Given this list of marker genes DDRGK1, NALF2, CREB3L1, ZSCAN26, GIPC1, DIRAS1, ARHGEF11, MBD3L5, CAMK2A, SLA2, DNMT3A, TNRC18 (NCBI Gene Id 84629), ADAMTS19 (NCBI Gene Id 171019), MBD6, SLC4A1, PTGFRN, KMT2D, ATP6V0A1, DPP9, BCL7A, ZBTB4, EPHA8, BCAM, SETBP1, BHLHE40, MEOX1, FAM222A, ANO10, FOXP4, SLC6A8, ARF3, ARPP19, COL5A3, B4GALNT1, TUBB, RALGPS1, DMPK, UBAP2, MLLT6, MAT2A, MBD3L4, HOXC4, LRFN2, RNF208, WAS, HELZ2, DUSP8, SYT7, MAVS, PRDM11, PLA2G2D, HNRNPUL1, PPP1R9B, CASTOR2, ZNF385A, C2CD2L, MYO18A, AR, RANBP10, ZNF764, BAZ1B, MTA1, HNF4A, PLEKHM1, NPTXR, UGT3A1, STX1B, SCRT1, NACC1, NPSR1, WFDC12, MOCS1, PBX2, ENTPD2, WDTC1 (NCBI Gene Id 23038), NFIX, STAT6, FBXO33, MARCHF4, AIF1L, STMN2, DLGAP3, LIPT2 (NCBI Gene Id 650826), GIT1, LDAH, ZBTB7A, SPTB, FASN, PAPPA2, CAMTA1, SLC7A1, SMARCC2, AGO1, ACER3, TNRC6A, HIC2 (NCBI Gene Id 23119), MYO7B, MAPK3, SAMD4B, NOVA2, MEF2D, ZNF574, GNPAT, LRCH4, ZFP36L1, HYOU1, DHX8, DUSP3, VAX2, GATAD2B, RAB3A, ERI3, JRK, SYNGAP1, CDC42EP1, MEX3A, RAMP2, DIAPH1, ZSWIM4, SERF2, SLAMF8, SH3PXD2A, MED8, SHFL, PPP1R10, CELSR2, RABL2A, PPP2R5B, SF3B3, CLIP2, RCE1, SLC22A11, MIGA2, NKAIN1, ARHGAP29, MBD3L2, MMP28, KSR2, ARRB1, ZNF275, MIF4GD, ZDHHC3, ARFGEF3, KCTD13, L1CAM, LENEP, NFIC, SIRPA, PCBP4, KCNQ4, SLC22A6, KIF20B, SKI, SAXO1, KLHDC7A (NCBI Gene Id 127707), LELP1, NFAM1, FAM240A (family with sequence similarity 240 member A), RUNX3, TRIM3, C12orf43, MLKL, VTI1A, DNAJB5, CREG1, RIMS3, RAB44, S100A1, TGM2, CBX7, DLK1, FCHSD1 (NCBI Gene Id 89848), TOM1L2, CMIP, TBC1D22B, SELL, WNT1, ATXN1L, DBP, TFAP2B, FIBCD1, ERGIC1, TFE3, SPIB, SGCD, TMEM104, SCAMP5, ELAVL3, SMG5, GAP43, EHMT2, GDI1, IQSEC2, MIER2, EFNA3, PLAGL2, IFFO2, CELF5, PDE1B, SLC35A2, SEPTIN9, DERL3, SLIT1, RAD1, TSC1, MBD3L3, MRPL49, MECP2, CELF3, ZMIZ1, GRK3, STMN3, CHD3, SLC6A17, ZNF703, APH1A, NFASC, here is a description of the gene set: studied in species Homo sapiens Human Gene Set: MIR92A_2_5P Genes predicted to be targets of miRBase v22 microRNA hsa-miR-92a-2-5p in miRDB v6.0 with MirTarget v4 prediction scores > 80 (high confidence targets). from publication Chen Y, Wang X (PMID 31504780)